The following is a description of a gene set: PI3K events in ERBB4 signaling studied in species Homo sapiens Human Gene Set: REACTOME_PI3K_EVENTS_IN_ERBB4_SIGNALING, and this is the list of marker genes: NRG2, NRG1, ERBB4, BTC, HBEGF (NCBI Gene Id 1839), NRG3, NRG4, PIK3CA, PIK3R1, EREG